The following is a description of a gene set: Human Gene Set: HP_ABNORMAL_CIRCULATING_GLUTAMINE_CONCENTRATION species: Homo sapiens Abnormal circulating glutamine concentration Any deviation from the normal concentration of glutamine in the blood circulation., and this is the list of marker genes: SLC7A7, GLUL, CA5A (carbonic anhydrase 5A), LIPT1, SLC25A13, TALDO1, ASL, NAGS, OTC, GLS, ASS1, COX16